The following is a description of a gene set: Human Gene Set: FOSTER_TOLERANT_MACROPHAGE_UP Toll-like receptors (TLRs) induce a multi-component inflammatory response that must be tightly regulated to avoid tissue damage. Most known regulatory mechanisms target TLR signalling pathways and thus broadly inhibit multiple aspects of the inflammatory response. Given the functional diversity of TLR-induced genes, we proposed that additional, gene-specific regulatory mechanisms exist to allow individual aspects of the TLR-induced response to be differentially regulated. Using an in vitro system of lipopolysaccharide tolerance in murine macrophages, we show that TLR-induced genes fall into two categories on the basis of their functions and regulatory requirements. We demonstrate that representatives from the two classes acquire distinct patterns of TLR-induced chromatin modifications. These gene-specific chromatin modifications are associated with transient silencing of one class of genes, which includes pro-inflammatory mediators, and priming of the second class, which includes antimicrobial effectors. These findings illustrate an adaptive response in macrophages and reveal component-specific regulation of inflammation. species: Mus musculus Class T (tolerizeable) genes: induced during the first LPS stimulation and either not re-induced or induced to a much lesser degree in tolerant macrophages. from publication Foster SL, Hargreaves DC, Medzhitov R (PMID 17538624), and this is the list of marker genes: RNF149, CXCL9, XAF1, MCHR1, PVR, TSPO, CLEC4E, NRIP2, IFT57, RAB20, CD38, SLC7A2, ZFAND3, TENT5C, SELL, C3orf70, CEP85L, CCL8, HLA-B, PEDS1, ATXN7L1, SMURF1, SLAMF9, ID3, ZDHHC2, JAG1, ZNF878, CXADR, GOSR1, SLFN12, BRDT, GLRX, SPATA31F1, SLC31A2, IL18BP, PITX1, C9orf43, WNK2, PPP3CC, GPR33, SMG1, NAV2, FAM111A, CYCS, HP, PHLPP1, TGFBI, RAB10 (RAB10, member RAS oncogene family), PLPP3, ASS1, TRIM23, IGSF6, ADHFE1, CD200, CLMP, IFRD1, LMO4, TANK, TNFRSF1B, CST7, AGTRAP, SLC7A8 (NCBI Gene Id 23428), KPNA4, SLC13A3, F10, RTN4R, BAK1, ETF1, HILPDA, CP, ID2, GALNT15, ZC3H12C (zinc finger CCCH-type containing 12C), NAIP, SGK1, RIOK3, GEM (GTP binding protein overexpressed in skeletal muscle), SLX4IP, LOX, SERPINB9, ANKRD66, PRKRIP1, IL1RN, SPIC, RNASET2, MS4A6A, BTG3, RASGRP1, LRRC8C, MSR1, PTGES, DCBLD2, CCDC71L, RAB32, ARHGAP8 (NCBI Gene Id 23779), ORM1, TMCC3, CFB, ELL2, ACSL1, FABP3 (NCBI Gene Id 337956), SLC31A1, BST2, CLN5, PPM1H, SELENOW, RGL1, GPR148, LCN2, MTHFD2, CFAP210 (NCBI Gene Id 129881), DNAJC1, GPR18, MCOLN2, CTTN (cortactin), THBS1, LRRC4, STAT1, SMAD6, SLC25A37, BST1, TREML2, PPFIA3, PLPP1, SYK, ORAI2, MARCO, MARCHF5, PRDX5, RHO, MTDH, PGAP2, FABP7, MREG, ITGAL, GPR61, FGL2, FBRSL1, SMAD7, PSMD10, CDC42EP2, TXNRD1, FPR1, SLC7A11, ADORA2A, ELK3, IRF7, RGS1, IGHG1, VN1R17P (NCBI Gene Id 441931), NUPR1, OAS3, SLC16A3, TMEM178A, MIR4435-2HG, PIK3AP1, MET, AOAH, FPR2, IFI44, TRAF3, IQSEC2, ISG20, ZDHHC18, RBPMS, CCDC68, IRAK3